The following is a description of a gene set: part of: SLC-mediated transport of organic anions Reactome Pathway: Organic anion transport by SLC5/17/25 transporters This event has been computationally inferred from an event that has been demonstrated in another species.<p>The inference is based on the homology mapping from PANTHER. Briefly, reactions for which all involved PhysicalEntities (in input, output and catalyst) have a mapped orthologue/paralogue (for complexes at least 75% of components must have a mapping) are inferred to the other species. species: Mus musculus electronically inferred by orthology from the curated human pathway, and this is the list of marker genes: Slc25a10, Slc5a8, Slc25a11